Given this list of marker genes NOTCH2, PCMTD2, USP34, CDIPT, DDX5, AREG, CLCN7, BTG1, TGFBR2, LAPTM5 (lysosomal protein transmembrane 5), RPS15A, PNISR, LEPROT (leptin receptor overlapping transcript), PRDM2, MAGED2, RPL34, TPP1, RUNX1, BTN3A1, RGS2, ITPKB, RPLP2, CLSTN1, ITGA2B, SGK1, EZR, RBMS1, RCE1, RPL37, TLE5, RPL32, MOB1A, TDRD3, ADD3, ARL4C, DAZAP2, AXIN1, SRSF6, BTG2, SATB1, RPL29 (NCBI Gene Id 6159), RPL10, HNRNPDL, CALM1, RPS27A, SYNE2, RPS20, TERF1, ATP6AP1, POU6F1, LEF1, MCL1, RPL13, SH3YL1, DGKA, BCL11A, PRKCQ, EXT1 (NCBI Gene Id 3966, exostosin glycosyltransferase 1), IL6ST, CAPN2, MCF2L, FAM168A, RGL2, TRAM2, PPM1H, CD37, GTPBP6, RGS10, FOXN3, CD247, ACP5, EIF3G, SDCBP, H3-3B, AKAP8, RBM39, ISG20, RBM38, ACVR2A, RPS16, SC5D, SYNE1, NUCB2, MOAP1, JOSD1, BRD8, DNAJB2, UBXN1, ARL2BP, TNK2, DDIT3, ABLIM1, MFGE8, RPS23, TMCO1, EIF1, TXNIP, RPS8, COL14A1, FYB1, TRIB2, ZBTB1, CXCR4, SORBS3, GPS2, CCNI, HOXA5, ATG13, ITGB8, HERC2P3 (NCBI Gene Id 8921), NUMA1, SNRNP70, RXRB, RGS1, CENPB, AMT, HEG1, RNF139, LEPROTL1, PI4KB, OSER1, CHD3, KAT7, FASN, LGALS8, AUTS2, RPL30, BLCAP, LITAF, MYH9, SNRK, MAP1A, IFFO1, MT2A, RPL36A, MZF1, ATXN7L3B, WTAP, TAX1BP1, PDE4B (NCBI Gene Id 5142), TPT1, SF3A1, EIF3A, RPS12, NME3, PER1, GADD45A, UBE2G2, SGSM2, RPS13, ICAM3, SPAG9, CIRBP, RANBP2, CTSK, ITGA6, CDC14A, SARAF, TCF7, RFX5, RPL23, FCGRT, MAN2B2, DGCR2, CTSW, CD47, PLCD1, DGKZ, TOB1, LSM14A, CTSO, SORL1 (sortilin related receptor 1), MAL, PTPRA, SETD1B, CYTH1, ZFP36L2, TPM2, MT1G, VAMP2, STK17A, HLA-E, CASP4, NXF1, TIMP1, SEC31B, DDX3X, NCOA1, ATP2B1, PIK3IP1, SFPQ, TRIM2, PPP6R2, BICRAL, SPOCK3, DNAJB6, FTH1, RPS28, RPL22, LAMP1, here is a description of the gene set: We found that a number of Tfh cells downmodulated BCL6 protein after their development, and we sought to compare the gene expression between BCL6-hi Tfh cells and BCL6-low Tfh cells. Human Gene Set: GSE24574_BCL6_HIGH_TFH_VS_TFH_CD4_TCELL_DN Genes down-regulated in BCL6 high follicular helper T cells (Tfh) versus all Tfh. studied in species Homo sapiens from publication Kitano M, Moriyama S, Ando Y, Hikida M, Mori Y, Kurosaki T, Okada T (PMID 21636294)